Given this list of marker genes Igfbp6, Hk2, Trip10, C3, Ttc19 (tetratricopeptide repeat domain 19), Col6a3, Txnip, Tanc1, Sema4a, Parp16, Pmm1, BC018473, Lgmn, Spp1, Slc2a1, Edem1, Igf2r, Itm2b, here is a description of the gene set: from publication Kasler HG, Verdin E (PMID 17470548) Genes down-regulated in DO11.10 cells (hybridoma) by expression of transciptionally activating form of HDAC7 and up-regulated by its transcriptionally repressing form. Histone deacetylase 7 (HDAC7) is highly expressed in CD4(+)/CD8(+) thymocytes and functions as a signal-dependent repressor of gene transcription during T-cell development. In this study, we expressed HDAC7 mutant proteins in a T-cell line and use DNA microarrays to identify transcriptional targets of HDAC7 in T cells. The changes in gene expression levels were compared to differential gene expression profiles associated with positive and negative thymic selection. This analysis reveals that HDAC7 regulates an extensive set of genes that are differentially expressed during both positive and negative thymic selection. Many of these genes play important functional roles in thymic selection, primarily via modulating the coupling between antigen receptor engagement and downstream signaling events. Consistent with the model that HDAC7 may play an important role in both positive and negative thymic selection, the expression of distinct HDAC7 mutants or the abrogation of HDAC7 expression can either enhance or inhibit the signal-dependent differentiation of a CD4(+)/CD8(+) cell line. Mouse Gene Set: KASLER_HDAC7_TARGETS_1_DN species: Mus musculus